Given this list of marker genes EPAS1, EPS8, PGF, PPP1R14A (protein phosphatase 1 regulatory inhibitor subunit 14A), COX4I2, COL4A1, EGFL6, SOD3, PTP4A3, NR2F2, ITGA1, MYLK, CSRP1, MAP1B, ARHGDIB, A2M (alpha-2-macroglobulin), ANGPT2, FRZB, ESAM, COL18A1, GJA4, CSRP2, ACTG2, TFPI, JAG1, SPARCL1, TPM2, NDUFA4L2, CNN1, HIGD1B, COL4A2, MEF2C (NCBI Gene Id 4208), CAV1, CRIP2, MGP, MYH11, ADIRF, PDGFRB, RGS5, NOTCH3, PLXDC1, MCAM, PLN, IGFBP7 (NCBI Gene Id 3490), MYL9, ACTA2, TAGLN, TINAGL1, CRIP1, TPPP3, here is a description of the gene set: Human Gene Set: GAVISH_3CA_METAPROGRAM_FIBROBLASTS_PERICYTE_LIKE In this study, an extensive analysis was conducted to define meta-programs (MPs) capturing intra-tumor heterogeneity across a spectrum of tumor types. The approach utilized non-negative matrix factorization (NMF) to analyze each cell type separately within individual tumor samples. This involved the analysis of malignant cells, macrophages, fibroblasts, endothelial cells, epithelial cells, T-cells, and B-cells. NMF was executed with varying parameter values (K=4, 5, 6, 7, 8, 9), thereby generating 39 programs for each cell type per sample. Each NMF program was summarized by the top genes based on NMF coefficients.\nRobust MPs were then delineated for each cell type using a set of stringent criteria, including recurrence within the same tumor, similarity to programs in other tumors, and non-redundancy within a tumor. Subsequently, these robust NMF programs were clustered (per cell type) based on Jaccard similarity, leading to the identification of MPs associated with each cell type.\nTo enhance the quality of the MPs, a refinement steps were undertaken, involving the removal of MPs suspected of reflecting low-quality data (with an overrepresentation of ribosomal proteins or mitochondrial-encoded genes), single-study inclusion, or similarity to miss-annotated cell types. from publication Gavish A, Tyler M, Greenwald AC, Hoefflin R, Simkin D, Tschernichovsky R, Galili Darnell N, Somech E, Barbolin C, Antman T, Kovarsky D, Barrett T, Gonzalez Castro LN, Halder D, Chanoch-Myers R, Laffy J, Mints M, Wider A, Tal R, Spitzer A, Hara T, Raitses-Gurevich M, Stossel C, Golan T, Tirosh A, Suvà ML, Puram SV, Tirosh I (PMID 37258682) Genes upregulated in subsets of cells of a given type within various tumors species: Homo sapiens